Given this list of marker genes SLC39A7, TKT, HPGD, RBM8A, COMT, IL7, PIGA, C5, ZNF750, GP1BB, UFD1, SEC24C, JMJD1C, MCCC2, CIB1, ARVCF, GPR101, TMC6, TMC8, AIP, BTD, PIK3CA, SLCO2A1 (NCBI Gene Id 6578), TBX1, RREB1, CARMIL2, HIRA, TRAF3IP2, here is a description of the gene set: Human Gene Set: HP_SEBORRHEIC_DERMATITIS Seborrheic dermatitis Seborrheic dermatitis is a form of eczema which is closely related to dandruff. It causes dry or greasy peeling of the scalp, eyebrows, and face, and sometimes trunk. studied in species Homo sapiens